Given this list of marker genes Gm15093, Hspa4, Stpg2, Pafah1b1, Caps2, Coch, Sestd1, Sgtb, Gm15107, Sbno1, Golm1 (NCBI Gene Id 70079), Dhx40, Cfap36, Mynn, Ppargc1b, Ppt1, Wdr36, Gm15085, Tcf4, Erg28, N4bp1, Gm15114, Spata6l, Desi1, Tbx4, Prkg2, Dlg1, Osbpl8, Dydc1, Acvr2a, Dffa, Ott, Pcdh15, Gm15127, Pcdh12, Gm15080, Tdrd6, Tmem185b, Ptgdr, Usp10, Fut4, Gal3st2c, Ccng1, Lpp, Ctnnd1 (catenin delta 1), Pfkfb2, Zfp677, Pex1, Bmpr2, Nsdhl, Thap1, Zfp735, Cyp4a12b, Ppp4r4, 1700093K21Rik, Zcchc3, Gm10439, Trim26, Epm2aip1, Fam168b, Gm15097, Luc7l2, Nap1l1, Ckmt2, Myg1, Trub2, Cst5, Ndst2, Thoc7, Gdi1, Ppm1e, Tpgs2, Ttc32, Asgr1, Ebna1bp2, Dhtkd1, Slc7a14, Tmem170, Mcph1, Flrt3, Dazap2, Ranbp6, Reln, Slitrk4, Rp1, Fgd4, Cyp4a12a, Chd6, Gm15091, Isca1, Rhag, Epc1, Cd72, Serpinb10, Luzp4, Lrif1, Hapstr1, Ythdf3, Daam1, Pdzrn4, Gulo, Ctsq, Tent5d, Lcp2, here is a description of the gene set: species: Mus musculus from publication Chen Y, Wang X (PMID 31504780) Genes predicted to be targets of miRBase v22 microRNA mmu_miR_6237 in miRDB v6.0 with MirTarget v4 prediction scores > 80 (high confidence targets). Mouse Gene Set: MIR_6237